The following is a description of a gene set: studied in species Homo sapiens Human Gene Set: GOBP_GLYCOSAMINOGLYCAN_METABOLIC_PROCESS The chemical reactions and pathways involving glycosaminoglycans, any of a group of linear polysaccharides composed of repeating disaccharide units., and this is the list of marker genes: NDST1, PGLYRP4, GUSB, CEMIP, SPAM1, ITIH1, XYLT2, STAB2, CHSY3, CHST12, B3GAT1 (NCBI Gene Id 964), CHST3, ITIH4, PDGFB, CLTC, CHST13, HAS2, B4GALT7, CD44, B3GAT3, HEXB, CHSY1, LYG2, LYVE1, FOXC1 (NCBI Gene Id 3666), XYLT1, HS3ST2, UGDH, DSE, ITIH3, IDS, CHST9, PGLYRP3, HEXA, PGLYRP2, CSGALNACT2, GALNT5, SGSH, SMPD3, DSEL, B3GAT2, IGF1, AP2A1, CYTL1, HS3ST3A1, ABCC5, SLC35B2, FGF2, ITIH2, HS3ST1, CHPF, GNS, IL1B, NAGLU, B3GALT6, GCNT2, HYAL3, HYAL2, PXYLP1, ITIH5, ITIH6, CHST7 (carbohydrate sulfotransferase 7), HMMR, TGFB1, EGF, HAS1 (NCBI Gene Id 3036), PGLYRP1, HYAL1, LYG1, HYAL4, CLN6 (NCBI Gene Id 54982), EXT2, CEMIP2, CSGALNACT1, NFKB1, CHPF2, TNFAIP6, EXT1, CHST11, HAS3, HS3ST3B1, IDUA (alpha-L-iduronidase)